Given this list of marker genes RIF1, SIRT6, DOT1L, EZH2, ATRX, HAT1, H3-3A, H3-3B, SIRT2, EZH1, here is a description of the gene set: Human Gene Set: GOBP_SUBTELOMERIC_HETEROCHROMATIN_FORMATION The compaction of chromatin into heterochromatin at the subtelomeric region. studied in species Homo sapiens